Given this list of marker genes Tc2n, Adss2, Ncoa6, Acp3, Msi2, Setd6, Prrx1, Fermt1, Arhgef6, Mzt1, Hspa5, Fjx1, Men1, Tent5a, Ube2ql1, Ccl22, Hmgcr, Ccdc73, Tmem158, Kmt5b, Fhad1, Plxna2, Rrp36, Slit3, Tollip, Dlst, Mrps2, Txn2, Nr3c2, Fam13b, Idh3a, Sash3, Stard6, Cfap298 (NCBI Gene Id 68001), Cdc73, Hsd3b1, Cul2, Dclre1a, Nup35, Rnf38, Bccip, Kifc3, Zfp383, Tmem154, Map3k2, Umps, Sycp3, Smad4, Flrt3, Hebp1, Tmem68, Canx, Abracl, Tm9sf2, Nup54, Galntl6, Ppp4r3b, Ncoa2 (nuclear receptor coactivator 2), Esm1, Tead1, Slc4a4, Slc30a10, Eva1a, Spata1, Macroh2a2 (NCBI Gene Id 404634), Rcn2, Clca2, Tmed7, Wdr11, here is a description of the gene set: Genes predicted to be targets of miRBase v22 microRNA mmu_miR_148a_5p in miRDB v6.0 with MirTarget v4 prediction scores > 80 (high confidence targets). species: Mus musculus from publication Chen Y, Wang X (PMID 31504780) Mouse Gene Set: MIR_148A_5P